Given this list of marker genes Sord, Gapdhs (glyceraldehyde-3-phosphate dehydrogenase, spermatogenic), Hibadh, Hsd17b8, Rnls, Gpd1, Aldh2, Glyr1, Ugdh, Sirt1, Cryl1 (crystallin, lambda 1), Idh1, Uxs1, Hsd11b2, Glud1, Sirt7, Ctbp1, Cyb5r3, Me1, Ldhb, Hpgd, Qdpr, Gpd1l, Me3, Adh7, Phgdh, Grhpr, Ahcyl, Nudt6, Aldh5a1, Htatip2, Aox1, Aox4, Parp14, Aldh1a1, Hadh, Cryz, Mdh1, Hadha, Ehhadh, Parp1, Aldh9a1, Me2 (NCBI Gene Id 225723), Idh2, Idh3a, Ldha, Bdh2, Sirt3, Idh3b, Sirt5, Ndufv1, Ahcy, Hsd17b10, Sirt2, Aox2, Idh3g, Sirt4, Dld, Gapdh, Hsd3b1, Sirt6, Aox3, Ctbp2, Aldh1a3, Adh4, Ndufs2, here is a description of the gene set: species: Mus musculus Binding to nicotinamide adenine dinucleotide, a coenzyme involved in many redox and biosynthetic reactions; binding may be to either the oxidized form, NAD+, or the reduced form, NADH. Mouse Gene Set: GOMF_NAD_BINDING